The following is a description of a gene set: Human Gene Set: chr9p24 species: Homo sapiens, and this is the list of marker genes: MTCO3P11, PDCD1LG2, RNU6-1327P, PLPP6, RPS27AP14, DOCK8-AS2, KANK1, MTND1P11, DOCK8, PPIAP33 (NCBI Gene Id 392285), PTPRD-AS1, RNF152P1, RFX3-DT, RPS3AP54, FOXD4, LINC01230, GLDC, CARM1P1, RNF2P1, CSNK1G2P1, PLGRKT, TCF3P1, CDC37L1, RNU6-694P, MIR1302-9, IL33, RCL1, ATP5PDP2, ZNG1A, MTND6P5, RPL12P25, DOCK8-AS1, HNRNPA1P41, RNA5SP279, GLIS3-AS2, BRD10, SLC1A1, GLIS3, MTCO2P11, SNRPEP2, ACTG1P14, RN7SL592P, GLIS3-AS1, MIR1302-9HG, MTATP6P11, SMARCA2-AS1, TPD52L3, DMRT2, WASHC1, EIF1P1, DMAC1, MTCO1P11, PDSS1P1 (NCBI Gene Id 100421847), INSL6 (NCBI Gene Id 82352), GPS2P1, SPATA6L, ENSG00000305801, SELENOTP1, CD274, RNU6-1073P, RANBP6, AK4P4, MLANA, UHRF2, RNU2-25P, INSL4, SMARCA2, RN7SL25P, PUM3, MIR101-2, KLF4P1, DMRT1, CDC37L1-DT, IGHEP2, PRELID3BP11, RN7SL123P, ERMP1, FAM138C, H3P29, RLN1, DDX11L5, LINC02851, LINC01231, VLDLR-AS1, MTND4P14, ENSG00000231902, DMRT3, RPL23AP57, RPL35AP20, ENSG00000286162, RIC1, RPL4P5, VLDLR (NCBI Gene Id 7436), ECM1P1, MTND5P14, JAK2, LINC01388, MIR4665, KCNV2, GTF3AP1, HMGN2P31, AK3 (adenylate kinase 3), KDM4C (NCBI Gene Id 23081), RFX3, RLN2, PGM5P3-AS1, RNU7-185P